Given this list of marker genes Tal1, 4930589L23Rik (NCBI Gene Id 75879), Gm16023, Ccdc117, Cdk11b, Or5m11, Pgk1, Mtr, here is a description of the gene set: Genes containing one or more binding sites for (Hhex) in their promoter regions (TSS -1000,+100 bp) as identified by GTRD version 20.06 ChIP-seq harmonization. Mouse Gene Set: HHEX_TARGET_GENES species: Mus musculus from publication Yevshin I, Sharipov R, Kolmykov S, Kondrakhin Y, Kolpakov F (PMID 30445619)